The following is a description of a gene set: Human Gene Set: GSE37301_MULTIPOTENT_PROGENITOR_VS_COMMON_LYMPHOID_PROGENITOR_DN studied in species Homo sapiens from publication Ramirez K, Chandler KJ, Spaulding C, Zandi S, Sigvardsson M, Graves BJ, Kee BL (PMID 22608498) Expression profiling of Rag2-deficient Ets1++ and Rag2-deficient Ets1-- mature NK cells and WT bone marrow progenitors, WT T cells, and WT Pro B cells Genes down-regulated in multipotent progenitors versus common lymphoid progenitors., and this is the list of marker genes: REM1, SCOC, TUT7, MAPK3 (mitogen-activated protein kinase 3), RNASEH2C, SMN1, GPD2, TUBB6, PEF1, EFNA1, CYP4A22, GSS, GSTM5 (glutathione S-transferase mu 5), SRI, ARID3A, RWDD4, RAMAC, ISG15, GLB1, IRF9, VEGFC, SPP1, DYRK1A, RIN2, SIGLEC1, GSTO1, TAF1D, APOC2, HS1BP3, EZR, RAF1, SPARCL1, TYMS, CRLF3, RRM2, ARL2BP, SNIP1, SELENOH, BLVRA, SENP3, USF1, C1QTNF12, DPH5, ACOT9, ST6GAL1, MECR, LMNB1, COL4A2, RPA1, NELFCD, PES1, UQCC1 (ubiquinol-cytochrome c reductase complex assembly factor 1), ADORA1, YPEL3, IRF7, NPDC1, GTF2B, GNL2, FES, VDAC1, HINT1, FAM32A, DCTN6, ABHD16A (NCBI Gene Id 7920), NVL, TLL1, CD59, GTF3C2, LYVE1, C9orf40, SPPL3, RGL2 (ral guanine nucleotide dissociation stimulator like 2), ASB3, EXOC7, PLIN2, PSMD8 (NCBI Gene Id 5714), STX12, SFMBT2 (Scm like with four mbt domains 2), PSTK, TAB2, OSMR, DDB1, NSMCE1, PTK6, TMEM68, HSDL2 (NCBI Gene Id 84263), SERPINB9, WFDC2, TGFB1 (transforming growth factor beta 1), VNN1, SBF2, CYP1A2 (cytochrome P450 family 1 subfamily A member 2), CLDN7, TMEM234, FAM114A2, ELMOD3, WNT5A, NUDT5, DLAT, LDHA, C5orf15, ART3, STBD1, UBE2A, RAB28 (RAB28, member RAS oncogene family), RND2, MFSD4A, FCGRT, ACTN1, CPT2 (carnitine palmitoyltransferase 2), IFT25, TBX3, ZW10, PIK3C3, ACADS, EIF4G1, STXBP2, LORICRIN, HMGA1, GPN2, RAP1GDS1, FBN1, RAD51D, CDK2, CARS1, ZFHX3, TSFM, POU6F1, ATF4, TRAFD1, TNFAIP8, MCOLN2, VRK1, EXOC4, FMNL1, ARF5, AMACR (NCBI Gene Id 23600), MYH1, UBE2L6 (ubiquitin conjugating enzyme E2 L6), IFT27, ECH1, ACTA1, INTS9, GRPEL2, CPEB2, DCPS, ATP6V1E1, EPCAM, IFIT1B, EXT2, DOCK7, MRPS26, LSM3, GAS6, PPIG, RBM14, LCP2, LGALS3BP, CCN1, FBXW5, TPST2, CEP350, HDAC5, SAP18, FADD, GHITM, KIF3C, SYNJ2, SPTLC2, USP18, RFC3, CLNS1A, NR2F6, CEBPZ, DGAT1, LONP2, ICAM1, PIK3CA, WBP4, ASAP1, TSNAX (NCBI Gene Id 7257), EZH2, S100A6, DLGAP4, SYT4, MAPKAPK5, ARMC10, THRAP3, DTYMK, COL13A1, CDT1, ZC3HC1, MAP4K4, CYC1, RTF2, FAM120A, IFNGR2, TARS2, ASAH1, SCARB1